The following is a description of a gene set: Human Gene Set: HP_APLASIA_HYPOPLASIA_OF_THE_MIDDLE_PHALANGES_OF_THE_HAND studied in species Homo sapiens Aplasia/Hypoplasia of the middle phalanges of the hand, and this is the list of marker genes: MEGF8, GJA1, PCNT, VAC14, INTU, MECOM, HOXD13, ERI1, RAI1, PTH1R, KMT2D, WNT5A, TRPV4, GMNN, PUM1, SLC26A2, MIR17HG, PDE4D, CEP152, ATP6V1B2, NIN, RUNX2, RBBP8, NSDHL, GNB2, EIF2AK3, IFT140, ERF, TBX5, RAB23, DVL1, BMP2, GDF5, IFT57, FGFR2, FIG4, ROR2, HOXA13, TFAP2B, FGFR3, LMNA (lamin A/C), PHF6, POLA1, COL10A1, PTDSS1, MBD5, KMT2A, IGF2, IHH, BMPR1B, DOCK6, MYCN, NEPRO, BHLHA9, COL2A1, KDM6A, NOG (noggin), BMP4, PUF60, FGFR1, SRCAP